The following is a description of a gene set: from publication Chen Y, Wang X (PMID 31504780) Human Gene Set: MIR7706 species: Homo sapiens Genes predicted to be targets of miRBase v22 microRNA hsa-miR-7706 in miRDB v6.0 with MirTarget v4 prediction scores > 80 (high confidence targets)., and this is the list of marker genes: SPNS2, BLCAP, TFAP2A, CSNK2A1, ZNF468, ADO, ALAS2, IQGAP1, ANO8 (anoctamin 8), ZBTB20, FOSB